Given this list of marker genes SLC26A3, here is a description of the gene set: Solute carrier (SLC) genes that code chloride (Cl-)/bicarbonate (HCO3-) exchanger proteins are the SLC4 and SLC26 families. The chloride anion exchanger SLC26A3 (aka down-regulated in adenoma, DRA) mediates electrolyte and fluid absorption in the colon. It is also localised to the midpiece tail membrane of sperm where it plays a role in Cl-/HCO3- homeostasis during sperm epididymal maturation. Defects in SLC26A3 cause congenital chloride diarrhea 1 (DIAR1), a disease characterised by watery stools containing an excess of chloride resulting in dehydration, hypokalemia, and metabolic alkalosis (Alper & Sharma 2013, Wedenoja et al. 2011). part of: SLC transporter disorders Reactome Pathway: Defective SLC26A3 causes congenital secretory chloride diarrhea 1 (DIAR1) studied in species Homo sapiens